The following is a description of a gene set: Human Gene Set: MIR6760_5P studied in species Homo sapiens from publication Chen Y, Wang X (PMID 31504780) Genes predicted to be targets of miRBase v22 microRNA hsa-miR-6760-5p in miRDB v6.0 with MirTarget v4 prediction scores > 80 (high confidence targets)., and this is the list of marker genes: MAPKBP1, ADAM19, CNKSR2, RABEP1, TPP1, ARL4A (NCBI Gene Id 10124), SEPTIN3, TMEM9, VTI1A, FRS2, INSL5, ANKRD45, FBXL7, DLST, CERS2 (NCBI Gene Id 63903), NALF1, ANKRD22, STARD9, ATF7, ZCWPW1, ADIPOR2, FGF2, SPINK14, IGF1R, TP53I11, GMNC, MED1, FAM171A1, CNOT4, UBQLN4, DACT1, CLEC4G (NCBI Gene Id 339390), HS3ST3A1, ZNF774, CHORDC1, KIN, NCOA2, DMBX1, AGO1, EGFR, STAMBP, NXF1, RSPO4, LHFPL3 (NCBI Gene Id 375612), SLC25A44, AKTIP (AKT interacting protein), ABCB8, PGBD2, CHST14, CALHM5, EFNA5, GOSR1, CREB3L2, KLRF1, TRIM3, FAM98A, NPTX1, CHIC1, MPIG6B, BACH1, TBCEL, RGS5, DDB1, RAP1GAP2, GID8, ZKSCAN4, GPATCH2L, HOXA10, KDM5B, KCNIP3, BAZ2A, RAB2A, SLC25A17, DMRTA1, GJA5, MTCL2, CEACAM5, RPGR, NOVA2, TMEM120A, CACNG6, PHF24, PCSK1, TIPARP, CTCF, CORO2B, ARHGAP19, COL11A2, CHPF, IGF2BP1, UMOD, DCAF8, STAT6, PRRT2, ZFP36L1, SLC17A7, MICAL2 (microtubule associated monooxygenase, calponin and LIM domain containing 2), NFAT5, GNAL, REL, WDFY3, SLFN12, OSBP, ANK1, HIPK1, PNN, VCPIP1, PAWR, ZMIZ1, WNT8B, MYRF, DLG2, GIGYF2, CAPRIN1, ICOS